The following is a description of a gene set: Mouse Gene Set: GOBP_SMALL_MOLECULE_BIOSYNTHETIC_PROCESS studied in species Mus musculus The chemical reactions and pathways resulting in the formation of small molecules, any low molecular weight, monomeric, non-encoded molecule., and this is the list of marker genes: Ip6k2, Bmp6, Lpcat3, Slc27a2 (solute carrier family 27 (fatty acid transporter), member 2), Gpi1, Gamt, Cyp11b1, Bglap, Bglap2, Pfkfb1, Abcd3, Gstm3, Baat, Oat, Fads6, Tmem135, Acsm4, Errfi1, Ndufa9, Dpyd, Mthfd1, Hsd17b7, Lepr, Akr1d1, Mtcl2, Cyp11b2, Acaa1b, Atp2b4, Sds, Apip, Wnt4, Coq2, Prkag1, Kynu, Cftr, Ptges, Sec14l2 (SEC14-like lipid binding 2), Il1b (NCBI Gene Id 16176), Cyp7a1, Cd74, Pck1, Alox5, G6pc1, ENSMUSG00000144291, Avp, Gapdh, Serpina12, Lpl (lipoprotein lipase), Apoa4, Dnph1, Adck2, Ppp4r3b, Idi2, Plod2, Fmo3, Gba1, Ggt5, Acaca, Dhfr, Snai1, Slc25a11, Abhd2, Lbr, Adcyap1r1, Tecr, Hpgds, Cyp2j6, Ces1e, Adk, Gstp-ps, Haao, Pycr2, Alox12, G6pd2, Hsd17b1, Adal, Foxo1, Aldh1a2, Mlycd, Enoph1, Coq5, Ip6k1, Cth, Slc25a10, Malrd1, Gnmt, Il6, Gck, Aldoa, Sik1, Bcat2, Lipg, Shmt2 (serine hydroxymethyltransferase 2 (mitochondrial)), Cyp24a1, Sc5d, Pdk4, Pnpo, Fasn, Got1l1, Ptgs1, Rbp1, Ces1b, Stard3, Acot7, Plp1, Wdr5, Pgam1, Cyp4a29, Abcd2, Gch1, Aass, Chst15, Tpk1, Sirt6, Sord, Fdft1, Fgf15, Pth1r, Wdtc1, Abcc1, Abca2, Impa2, Gcg, Oxsm, Ces1c, Rdh9, Bhmt1b, Acsl3, Ifng, Eif6, Alox8, Pgp, Dkk3, Mdh1, Hmgcll1, Cyp19a1, Rac1, Akr1c18, Prkag2, Apob, Usp7 (ubiquitin specific peptidase 7), Mif, Por, Hacd2, Brca1, Per2, Bhmt, Pycr3, Psph, Mid1ip1, Ada (NCBI Gene Id 11486), Snai2, Scd4 (NCBI Gene Id 329065), Qng1 (NCBI Gene Id 70153), Cyp4a14, Abcd1, Pla2g3, Rbp4, Coq7, Pex2, Amacr, Fabp5, Fmo1 (NCBI Gene Id 14261), Pla2g10, Fgf1, Aloxe3, Otc, Cd244a, Eno1, G6pdx, Trib3, Cbs, Pla2g4a, Ntsr1, Dgat2, Acsm1, Cyp27a1, Ggcx, Elovl5 (ELOVL fatty acid elongase 5), Hprt1, Kmo, Bcl10, Sptlc1, Nus1, Sephs1, Atf4, Fbp2, Inhba, Ces1h, Srebf1, Myh9, Dhrs9, Nsdhl, Ces1g, Acadvl, Aldh8a1, Pnpla8, Mtap, Gatm, Erlin1, Sirt7, Extl3, Prps1, Gprc6a, Nr1h2, Htd2, Gad2, Cyp7b1, Cyp51, Asl, Gls2, Ppip5k1, Klhl25, Ep300, Ido1, Acsl4, Car5a, Ugt1a6a (NCBI Gene Id 94284), Mpo, Coq4, Lipa, Mri1, Ldhc, Sco1, Alox5ap, Glul (NCBI Gene Id 226521), Aasdhppt, Ppp4r3a, Tk1, Anxa1, Itpka, Nans, Itpkb, Elovl4, Abcg1, Avpr1b (arginine vasopressin receptor 1B), Carns1, Erlin2 (ER lipid raft associated 2), Plod3, Ilvbl, Edn2, Decr2, Scap, Erfe, Fdps, Slc19a3 (solute carrier family 19, member 3), Agxt2, Acadl, Lipc, Apoa1 (apolipoprotein A-I), Arpp19, Abat, Cthrc1, Cyp4a31, Thtpa, Acly, Zfp692, Aprt, Mthfr, Slc35b4, Mthfd2l, Fgfr4, Pnliprp1, Gpt, Ceacam1, Fbp1, Tnf, Tm7sf2, Mcat, Ptafr, Cry1, Dhdds, P2ry6, Hsd17b8, Scp2, Sptlc3, Hsd17b10, Ass1, Crtc2, G6pc3, Gper1, Gfi1, Dctd, Gpt2, Acsm2, Ldha, Cdo1, Ptgds, Slc25a12, Pth, Kdm3a, Tha1 (threonine aldolase 1), Prxl2b, Pgm2, Bhmt2, Ubiad1, Mapk1, Apoa5, Lta4h, Mapk9, Prox1, Abhd3, Prmt3, Impa1, Ptges2, Abcg4, Gnai1, Cln3, Prkaca, Ptgs2, Fa2h, Bmp2, Mst1, Pklr, Hmgcs2, Sphk1, Pmvk, Pnp, Pltp, Cbr4, Ptges3, Upb1, Sesn2, Ebp, Mup1, Scd1, Acot8, Rtn4ip1, Star, Pts, Itpkc, Eno2, Gpd2, Plcg2, C1qtnf3, Spr, Mup3, Ces1d, Coq6, Srr, Sptssa, Slc1a3, Ak1, Got2 (glutamatic-oxaloacetic transaminase 2, mitochondrial), Rdh19, Nr1d1, Elovl1, Acsm5, C1qtnf12, Aldoc, Tpi1, Hif1a, Npc1l1 (NPC1 like intracellular cholesterol transporter 1), Rdh1, Agxt, Gstm4, Ehhadh (enoyl-Coenzyme A, hydratase/3-hydroxyacyl Coenzyme A dehydrogenase), Fads2b, Ces1a (carboxylesterase 1A), Gstm6, H6pd, Pcbd2, Mtrr, Ogt, Aldh1a3, Mup4, Acsbg2, Hnf1a, Acsbg3, Vkorc1, Lias, Gstm1, Insig1, Gsto1, Mup2, Asnsd1, Hmgcl, Mvk, Cyp27b1, Uros, Nr3c1, Hacd4, Ranbp2, Hsd17b4, Kat2b, Moxd1, Npy1r, Lpgat1, Pgd, Coq8a, Acsbg1, Ubr4, Ippk, Hacd1, Ndufab1, Hsd17b3, Supt20, Oprm1, Rdh10, Sirt5, Adi1, Kat2a, Gstp2, P2ry1, Gpr146, Daglb, Atf3, Slc27a5, Mup11, Rest, Mas1, Stard4, Slc19a2, Ltc4s, Reg3g, Prg3, Mvd, Pla2g4f, Ggt1 (gamma-glutamyltransferase 1, NCBI Gene Id 14598), Gstm7, Gulo, Lhcgr, Moxd2, Park7, Srd5a3, Dbh, Gad1, Avpr1a (NCBI Gene Id 54140), Cyp8b1, Ipmk, Aldh1a1, Aldh18a1 (aldehyde dehydrogenase 18 family, member A1), Egr1, Acadm, Gls, Ip6k3, Srebf2, Elovl2, Agk (acylglycerol kinase), Pecr, Slc45a3 (solute carrier family 45, member 3), Hacd3, Xpc, Alox15, Acox1, Ces1f, Prkab1, Ugp2, Plek, Coq9, Prkaa2, Asns, Ephx1, Fads3, Agt, Cyb5r3, Pcx, Gapdhrt, Apoe, Xiap, Pptc7, Dhcr24, Acsm3, Nanp, Pdxk, Acacb, Paqr3, Tecrl, Coq8b, Gapdhrt2, Coq3, Noxred1, Stk11, Nfkb1, Sptssb, Akr1b1, Aqp8, Mup5, Cyp4a10, Rdh16, Mgst3, Obp2a, Rgn, Pcbd1, Dhcr7 (7-dehydrocholesterol reductase), Srd5a2, Idi1, Bmp5, Acss2, Sod1, Sephs2, Acsf3, Qki, Pla2g1b, Scd3, Clk2, Hoga1, Cad, Nnmt, Mthfd2, Dgkq, Aldob, Tcf7l2, Sphk2, Nt5e, Pnliprp2, Cyp4a12a, Plcd1, Prkg1, Nr1h3, Ppara, Prkaa1, Pah, Syk, Bin1, Pla2g5, Edn1, Pgam2, Lep, Ptpn2, Hmgcs1, Nags, Slc25a13, Mecr, Mdh2, Ceacam2, Pdss2, Prkab2, Uevld (NCBI Gene Id 71499), Fads1, Ppip5k2, Cyp4a12b, Ppargc1a, Slc38a1, Pgk1, Clcn2, Pnlip, Prkag3, Acsl1, Pkm, Abhd1, Cyp2r1, Apoc2, Mthfd1l, Acmsd, Ptges3-ps, Gpd1, Slc37a4, Spp1, Mtr, Apoc1, Acer3, Pibf1, Hao1, Htt, Acss1, Sirt2, Gstp1, Acer2, Asah2, Gnpda1, Dcaf5, Ptgis, Pla2g2a, Acox2, Lss, Got1, Gne, Apoc2l, Mbtps2, Slc25a19, Thnsl2, Pgk2, Rdh16f2, Phgdh, Acer1 (NCBI Gene Id 76439), Snca, Olah, Mgst2, Pdk2, Mgll, Gip, Ldhb, Dtymk, Mlxipl, Fads2, Cyp2c23, Shmt1 (NCBI Gene Id 97731), Gstm2, Apoc3, Adipoq, Ddb1, Dab2, Slc39a14, Sptlc2, Elovl6, Pou1f1 (POU domain, class 1, transcription factor 1), Elovl7, Myo5a, Csad, Psat1, Hmgcr, Cyp39a1, Tbxas1, Msmo1, Dkkl1, Lgsn, Insig2, Isyna1, Cmtm2a, Fcer1a, Plcg1, G6pc2 (glucose-6-phosphatase, catalytic, 2), Scd2, Sirt1, 3110082I17Rik, Bcat1, Creb1 (NCBI Gene Id 98624), Degs1, Cyp4a32, Gstp3, Akr1a1, Asah1, Rfk, Cyp4a30b, Pdss1, Elovl3, Alox12b (arachidonate 12-lipoxygenase, 12R type), Cyp1a1, Acaa1a, Hsd17b12, Nln, Pycr1, Ugdh, Cacna1h, E2f1 (NCBI Gene Id 13555), Qdpr, Pck2, Hnf4a